The following is a description of a gene set: An inflammasome complex that consists of three components, NLRP3 (NALP3), PYCARD and caspase-1. It is activated upon exposure to whole pathogens, as well as a number of structurally diverse pathogen- and danger-associated molecular patterns (PAMPs and DAMPs) and environmental irritants. Whole pathogens demonstrated to activate the NLRP3 inflammasome complex include the fungi Candida albicans and Saccharomyces cerevisiae, bacteria that produce pore-forming toxins, including Listeria monocytogenes and Staphylococcus aureus, and viruses such as Sendai virus, adenovirus, and influenza virus. Human Gene Set: GOCC_NLRP3_INFLAMMASOME_COMPLEX species: Homo sapiens, and this is the list of marker genes: DDX3X, CASP1, CARD8, NLRP3, PYCARD, GSDMD, DHX33, NLRP1